The following is a description of a gene set: Mouse Gene Set: REACTOME_PHASE_1_INACTIVATION_OF_FAST_NA_CHANNELS Phase 1 - inactivation of fast Na+ channels studied in species Mus musculus, and this is the list of marker genes: Kcnd2, Kcnd1, Kcnip4, Kcnip2, Kcnd3, Kcnip1, Kcnip3